The following is a description of a gene set: Abnormality of the ovary Human Gene Set: HP_ABNORMALITY_OF_THE_OVARY species: Homo sapiens An abnormality of the ovary., and this is the list of marker genes: MSH6, BBS2, PALLD, FGFR2, DHX37, SEC23B, CCDC28B, GATA4, CAV1, PPP1R12A, BNC1, POLE, BRCA1, WT1 (NCBI Gene Id 7490), MID1, MSH4, LHB, BBS5, FGF8, NUP107, EWSR1, ATM, PLG, CFAP418, WNT10A, RPS20, RFC2, ERBB2, ERAL1, WRN, CEP19, PTCH1, FOXL2, OFD1, SPIDR, HROB, FLI1, PIGG, VAMP7, NDNF, CDKN2A, POLD1, SLC37A4, PMS2, PROKR2, POLR3H, ARL6, PATL2, STAG3, ZFPM2, ZSWIM7, ESR1, AGPAT2, STOX1 (storkhead box 1), RNF43, PSMC3IP, TBL2, NOBOX, PIK3R1, MMP2, PDE11A, SDHD, TP53, MMP14, NELFA, ELN, ZPR1, WEE2, KLLN, FOS, CYP19A1 (cytochrome P450 family 19 subfamily A member 1), CYP11B1, PRKN, TTC8, RAD50, SUFU, BBS4, ZFTA, TGFBR2, SPRY4, DHH, SEMA4A, BBS10, TMEM270, PROK2, FGF17, SCAPER, SDHC, FSHR, GNAS, SDCCAG8, EIF4H, RAD51, RAD51C, LZTFL1, BRCA2, CTBP1, STX1A, IDH2, WNT4, MT-CYB, IFT27, HS6ST1, PLIN1, WDR11, SOX9, CLPP, MBD4, SETD2, TRIM32, BAZ1B, RAD51D, MRPS22, LMNB2, PTCH2, BBS9, GTF2I, ALMS1, IFT172, PTPN11, MKS1, SPRED1, PHKG2, TRPV6, TBX1, SOX3, LIPE, SETBP1, PLAAT3, METTL27, NCF1, PMM2, AKT2, MSH2, DICER1, HFM1, BARD1, IDH1, LARS2, DUSP6, WWOX, SDHB, TP63, MDM2, CLIP2, RABL3, NBN, NTHL1, KRAS, BBIP1, KEAP1, CHEK2, AR, HARS2, FLT1, EPCAM, LIMK1, GNRHR, CDH1, CPLX1, FOXE1, GTF2IRD1, MYC, PIK3CA, NR5A1, LEP, VPS37D, NSMF, KISS1, MRE11, PPARG (NCBI Gene Id 5468), PTEN, TUBB8, LMNA, LEPR, SRY, GNRH1, CAVIN1, SMAD4, CHD7, MAP3K1 (NCBI Gene Id 4214), BBS1 (NCBI Gene Id 79702), LETM1, PRKAR1A, MKKS, F7, NHLH2, CEP290, CBX2, MCM8, INSR, NR0B1, FIGLA, CYB5A (cytochrome b5 type A, NCBI Gene Id 1528), CIDEC, BRIP1, BMPR1A, MSX1, AKT1, CYP17A1, BBS12, IFT74, PHKA2, FKBP6, PMS1, ANTXR2, MUTYH, HNF1A, MLH1, FGFR1, NPHP1, OPCML, C14orf39, BMP15, POR, WDPCP, USF3, PAX6, SCLT1, TAC3, DNAJC30, TACR3, GTF2IRD2, DMRT1, NSD2, KISS1R, CORIN, PRLR, PALB2, MSH3, PHKB, CTNNB1, PANX1, ALG9, STK11, BSCL2, BBS7, BUD23